Given this list of marker genes STMN1, ZNF781, COQ3, PPP5D1P, SLC5A9, CSNK1A1P1, MKI67, BUB1, ABCG1, GCSAML, SLC2A1, CCNB2, PDPR, SOX7, VAT1, KIF27, NIPSNAP1, ANLN, YY2 (YY2 transcription factor), PTAFR, FLNB, SERPING1, CENPS, LVRN, BMS1P20, DYNC2I2, REXO5 (NCBI Gene Id 81691), SCARF1, WDHD1, FGGY, RASAL2 (RAS protein activator like 2), E2F5, C10orf55, LINC00865, PCDHGA10, ATP13A3-DT, CT83, LDHC (lactate dehydrogenase C), SLC16A10, DEPDC1B, OIP5, MAFK, GUSBP11, ASF1B, GIMAP6, ZNF608, KIF4A, SLC9B2, CCDC141 (coiled-coil domain containing 141), PLPPR5-AS1, MIR3976HG, EVI2A (ecotropic viral integration site 2A), ESPL1, LEPROT, VRK1, PRSS55, UBL7-DT, SNORA68, SPATA22, LPCAT4, RIMKLB, MAGEA11, RIMS3, APBB3 (amyloid beta precursor protein binding family B member 3), BTBD16, CYP24A1, STIMATE, PARPBP, UBE2T, CIB4, CCNE2, FEN1, RAB40A, SAGE1, CENPF, ADH1C, TEKT4P2, BIRC5, TMEM52B, SEC11C, SLITRK6, TTK, SELENOP, CLRN3, TMEM45A, SORCS3, FOXE1, IRGM, ID1, SPC25, SOSTDC1, PTPRU, NEIL3, FOXE3, CORO1C, HS2ST1, DEFT1P, IGFBPL1 (NCBI Gene Id 347252), PDHA2, SP8, ENSG00000290598, RAD51AP1, SSPN, RCBTB2, SLC28A2, FAM83D, ENPP3, CLEC7A, SLC16A14, SMCO4, GNMT, MAMSTR, DPY19L1P1, AK5, SFXN2 (NCBI Gene Id 94082), RAD51, TOP2A, GLT8D1, MTFR2, EMC9, PCDHGB7, KIF11, IDO2, SIGLEC1, DSEL, OVGP1, AHI1, KIF18B, NUF2, MME, TSSK3, SAXO2, DNER, DIAPH3, ATP2B1-AS1, CEP55, AURKB, NDC80, PSME4, BCL2L14, TMEM200A, RDM1P5, SLC35F3, TROAP, FBXO10, MARCHF3, KIF20A, CNNM2, RALA, DEUP1, RHEX, PHACTR3, TST, CENPA, CDCA5, TBX3, KNL1, POLQ, TBC1D27P, DLGAP5, MIR9-1HG, DNAI7, PTTG1, CKAP2L, ALDOC, MIS18BP1, CDCA2, SLC30A1, SPOCK3, SPC24, FOXM1, KIF14, ARHGAP42, PMCH, THPO, SUCNR1, C1QTNF6 (NCBI Gene Id 83847), PABPC1L2B, HPD, CRNDE, NUSAP1, SMG1P5, ARMC10, TRERF1, DEPDC1, RMI2, CIT, CEP43, SPAG5, LCNL1, MIR101-1, TIAM2, here is a description of the gene set: Murine Cytomegalovirus (MCMV) infection leads to early activation of various immune cells, including B and T lymphocytes, before the actual initiation of antigen-specific adaptive immunity. This activation is partly driven by innate cytokines, including type I interferon (IFN), which are induced early after infection. The objective of this study was to address the role of type I IFN in shaping early/innate B and T cell responses to a primary acute viral infection. In order to decipher the specific impact of IFN-I on cell subsets, we performed a genome-wide expression analysis on WT splenic B and CD8 T lymphocytes isolated from C57BL/6 mixed bone marrow chimera mice. This study complements series GSE39555, which focused on early responses of NK cells and of the two subsets of conventional dendritic cells. studied in species Homo sapiens Human Gene Set: GSE45365_WT_VS_IFNAR_KO_BCELL_DN Genes down-regulated in B lymphocytes: control versus primary acute viral infection.